The following is a description of a gene set: Genes having at least one occurrence of the motif NRNGNGCGCGCWN in the regions spanning 4 kb centered on their transcription starting sites. This matches the ZFP161 transcription factor binding site V$ZF5_B (v7.4 TRANSFAC). species: Homo sapiens Human Gene Set: ZF5_B, and this is the list of marker genes: RNF125, RBM10, CEP63, TIGD2, NAV2, ETF1, THRA, TLE3, RAPGEFL1, NEUROG1, TMEM145, HNRNPD, SEMA6A, NDUFA4, UTP18, MTMR4, SLC26A10P, GPHN, RALB, TRA2B, MAGIX, CIDEB, WNT5A (Wnt family member 5A), PDGFB, RHEBL1, VEGFA, NCOA6, ABCA2, RORA, ANAPC13, GRHL2, PEX11B, HOOK2, ZNF703, GRIK3, TRMT9B, FLT4, CYP26A1, GFRA1, BHLHE40, CDKN2C, PITX2, EFS, METTL16, EPB41L4B, CPSF7, OPA3, FAP, CLOCK, CA7, PITX3, FGF12, DGKZ, PLCB1, EPC1, AP5B1, PATZ1, THOC1, TAF11, CLDN11, HTATSF1, ZIC2, STIM1, PSMD2, ENHO, ZBTB5, SH3BP4, NLGN3, FOXA2, PCDHGC3, KCTD4, MRPS5, TMEM135 (transmembrane protein 135), SCAF8, SPEN, HHIP, DENND6A, PLXNC1, CBX2, LMF2, NLK, SYNCRIP, SRCIN1, FUT8, MECP2, PPP3CA, PRR16, ZNF668, SDHAF2, PDE10A, ANKS1A, NEURL1, POLE4, ZDHHC15, SCRT2, SLC9A7, FGFR3, WDR1, NCOA2, AKT2, TRIB2, NHS, ITPR3, LGI3, MTMR3, ZNF804B, CRTAC1, ZNF646, KDM1A, TAOK2 (TAO kinase 2), GRIN3A, CACNG7, CDK9, POLR3G, KCNH4, MEIS2, JUP, RBKS, POU4F3, TSPAN7, EN1, OBI1, DPEP3, HR, H1-10, LINC02908, EIF2B4, C8orf82, PTPRG, SLC6A7, FAF1, RBPMS, CREBZF, EBAG9, PRKAR2A, LSM5, OTX1, DST, B4GALT2, RASGRP1, TIGD3, MACROH2A2 (macroH2A.2 histone), POU3F3, IGF2BP1, PRR14, SLC12A5, MT3, ANKRD35, NF2, NYAP1 (neuronal tyrosine phosphorylated phosphoinositide-3-kinase adaptor 1), GAP43, XYLT2, NR2E1, RFX4, RAB10, SV2B, SLC4A2, CYRIB, AFG3L1P, IGF2BP3, TRIM33, DNAJC22, VCP, NCOA5, BCL2L1, NAT8L, ASIC1, MARCKS, INSM1, KCNAB3, ADRA2C, ABLIM3, RPS6KA2, BAHD1, RHBDF1, LHX2, PRR7, CPNE1, NUDT16L1, DDIT3, NR2F6, JUNB, ADGRL2, SSH2, NRG2, DIAPH1, BCL7A, RNF207, ZBTB17, SNX17, ZNF827, PDIK1L, RBM14, NRXN1, WNT4, QRICH1, ELAVL3, ZFP91, ZNF410, POU4F1, MAPRE1 (microtubule associated protein RP/EB family member 1), CDK5, MAT2A, CUL5, MBLAC2, GNRHR2, FMR1, CDON, DDX1, PORCN, NFYC, GABRA3, GON4L, JADE2, TBC1D20, GEN1, STMN1, COL11A2, PRRG1, PKN2, KIF7, DLL4, MAZ, PSD, SREBF2, BABAM2, PPA2, MYCL, NCAPH2, SYT7, PGM2L1, MTHFD2, CBX6, DLX5, FBXL19, ZNF398, GCLC, EFNA4, OAZ2, TFAP4, CENPBD1P, PPM1A, FGF13